Given this list of marker genes Ndst1, Cyp2d9, Lmo1, Loxl1 (NCBI Gene Id 16949), Med26, Adh7 (NCBI Gene Id 99597), Gars1, Il15, Nnmt, Igf2r, Alppl2, Macroh2a1, Jun (jun proto-oncogene), Fbln5, Camk2a (calcium/calmodulin-dependent protein kinase II alpha), Enah, Asns, Pfn2, G3bp1, Slc7a1, Gcnt1, Acp3, Tiam1, Emilin1, Camk2n2, Upp1, Gabpb1, Cdk2ap1 (cyclin dependent kinase 2 associated protein 1), Tax1bp3, Tgfb1, Arf4 (ADP-ribosylation factor 4), Cebpb, Tspan7, here is a description of the gene set: from publication Pos Z, Wiener Z, Pocza P, Racz M, Toth S, Darvas Z, Molnar V, Hegyesi H, Falus A (PMID 18339882) Genes corresponding to the histamine response network. studied in species Mus musculus Mouse Gene Set: POS_HISTAMINE_RESPONSE_NETWORK We previously showed that transgenic enhancement of histamine production in B16-F10 melanomas strongly supports tumor growth in C57BL/6 mice. In the present study, gene expression profiles of transgenic mouse melanomas, secreting different amounts of histamine, were compared by whole genome microarrays. Array results were validated by real-time PCR, and genes showing histamine-affected behavior were further analyzed by immunohistochemistry. Regulation of histamine-coupled genes was investigated by checking the presence and functional integrity of all four known histamine receptors in experimental melanomas and by administering histamine H1 receptor (H1R) and H2 receptor (H2R) antagonists to tumor-bearing mice. Finally, an attempt was made to integrate histamine-affected genes in known gene regulatory circuits by in silico pathway analysis. Our results show that histamine enhances melanoma growth via H1R rather than through H2R. We show that H1R activation suppresses RNA-level expression of the tumor suppressor insulin-like growth factor II receptor (IGF-IIR) and the antiangiogenic matrix protein fibulin-5 (FBLN5), decreases their intracellular protein levels, and also reduces their availability in the plasma membrane and extracellular matrix, respectively. Pathway analysis suggests that because plasma membrane-bound IGF-IIR is required to activate matrix-bound, latent transforming growth factor-beta1, a factor suggested to sustain FBLN5 expression, the data can be integrated in a known antineoplastic regulatory pathway that is suppressed by H1R. On the other hand, we show that engagement of H2R also reduces intracellular protein pools of IGF-IIR and FBLN5, but being a downstream acting posttranslational effect with minimal consequences on exported IGF-IIR and FBLN5 protein levels, H2R is rather irrelevant compared with H1R in melanoma.